The following is a description of a gene set: electronically inferred by orthology from the curated human pathway This event has been computationally inferred from an event that has been demonstrated in another species.<p>The inference is based on the homology mapping from PANTHER. Briefly, reactions for which all involved PhysicalEntities (in input, output and catalyst) have a mapped orthologue/paralogue (for complexes at least 75% of components must have a mapping) are inferred to the other species. Reactome Pathway: Synthesis of PIPs at the Golgi membrane species: Mus musculus part of: PI Metabolism, and this is the list of marker genes: Pi4k2a, Fig4, Arf1, Pik3c2a, Pi4ka, Tpte, Inpp5e, Ocrl, Pik3c3, Sacm1l